Given this list of marker genes NRG1, NKX2-5, C10orf71, TNNC1, BMPR2, PPP1R13L (protein phosphatase 1 regulatory subunit 13 like), S1PR1, ZMPSTE24, FKBP1A, IFT172, SOX18, MIR1-1, SOX4, EGLN1, ZMIZ1, PKD2 (polycystin 2, transient receptor potential cation channel), FGF8, TGFB1, OVOL2, FOXN4, TBX2, NOTO, EPHB4, SETDB2, NPY1R, RARB, DKK1, CLUAP1, JUN, RBM15, MIR17, CLDN5, DLC1, PDCD4, FOXF1, NPHP3, PROX1, HIF1A, ATF2, SPRY1, TMED2, ROBO1, MTOR, TGFB2, CPLANE2, RYR1, BMP7, NRP1, ISL1, SEC24B, MIR17HG, DSP, XIRP2, MESP1, CITED2, POU4F1, ILK, ADAMTS19, NDRG4, NOTCH1, MYBPC3, GSK3A (glycogen synthase kinase 3 alpha), C2CD3, WNT3A, SMAD6, PITX2, MYL3, SMARCD3, NIPBL, FGFR2, BMP5, MSX1, HEY2, HAND1, MSX2, ASXL1, IFT57, ASB2, MYH7, CCN1, SOX9 (NCBI Gene Id 6662), EDN1, NAGLU, MIB1, GREB1L, ELN, ID2, SMAD3, ADGRG6, ADAMTS1, AHI1, TNNI3, CDC42, HEYL, HEY1, PSEN1, CPE, IFT52, HES1 (hes family bHLH transcription factor 1), ANKRD1, ROBO2, WNT2, CAV3, EDNRA, MIR21, NODAL, PRICKLE1, ACTC1, SRF, NOTCH2, CRKL, DNAAF1, LBX1, RYR2, SIX1, SEMA3C, MIR19B1, KCNJ8, UBE4B, LRP2, DNAH11, RAC1, LEFTY1, BMPR1A, FGFRL1, COL11A1, HAND2, OLFM1, EXT1, PARVA, TNNT2, EFNA1, ABCC9, FOLR1, HAS2, TWIST1, BMP10, DCHS1, GATA5 (NCBI Gene Id 140628), SLIT2, CTNNB1, JAG1 (jagged canonical Notch ligand 1), CCDC103, GATA6, RTN4, DAG1, BMP2, ARL13B, TGFBR2, STIL, TNNI1, NRP2, TBX20, BBS7, TH, TEK, DHRS3, ALDH1A2, MIR19A (NCBI Gene Id 406979), ZFPM1, ADAM15, DLL1, VANGL2, DVL1, TBX5, MKS1, SHOX2 (NCBI Gene Id 6474), NEDD4, SFRP2, TBX19, WNT5A (NCBI Gene Id 7474), COL5A1, WNT16, GRHL2, ACVRL1, EVA1A, SNAI2, TGFBR3, POU5F1, NOG, DVL2, TAB1 (TGF-beta activated kinase 1 (MAP3K7) binding protein 1), NPY5R, TREX1, TGFBR1, NOS3, YAP1, PLXND1, RNF207 (ring finger protein 207), MKKS, NACA, SOX11, SAV1, RBP4, PTCH1, GAA, CCDC40, NSD2, SMAD2, FOXH1 (forkhead box H1), PTK2, TBX3 (NCBI Gene Id 91834), SMAD7, MIR195 (microRNA 195), TCAP, SNAI1, SOS1 (SOS Ras/Rac guanine nucleotide exchange factor 1), NPY2R, MYLK2, ADAMTS5, PIM1, SYNPO2L, FKRP, TBXT, SUFU, BBS5, GJA5, APLNR, FOXC2, EMP2, GATA4, TP53, RBPJ, INSR, MYH6, CHD7, SHH, MDM2, MDM4, MED1, FHL2, MESP2, RARA, ADPRHL1 (ADP-ribosylhydrolase like 1), ENG, FZD2, PKP2, HTR2B, TTN, SMO, APC, AXIN2, SMAD4, RBM20, MEF2C, MEGF8, FOXC1, FZD1, WNT11, ALPK2, COL2A1 (collagen type II alpha 1 chain), FLRT2, TEAD2, SOX17, IHH, EYA1, MICAL2, SLIT3, HEG1, TGFB3, DLL4, CCDC39 (coiled-coil domain 39 molecular ruler complex subunit), LEMD2, ARID2, MYL2, BMP4, PTCD2, GATA3, ZIC3, TPM1, MIR20A, TMEM100, TBX1, VEGFA, CERT1, ACVR1, ZFPM2, CCM2L, here is a description of the gene set: Human Gene Set: GOBP_HEART_MORPHOGENESIS studied in species Homo sapiens The developmental process in which the heart is generated and organized. The heart is a hollow, muscular organ, which, by contracting rhythmically, keeps up the circulation of the blood.